The following is a description of a gene set: studied in species Homo sapiens Human Gene Set: REACTOME_ACETYLCHOLINE_REGULATES_INSULIN_SECRETION Acetylcholine regulates insulin secretion, and this is the list of marker genes: PLCB1, CHRM3, PLCB3, GNAQ, GNA15 (G protein subunit alpha 15), GNA14 (NCBI Gene Id 9630), PRKCA, MARCKS, PLCB2, GNA11